Given this list of marker genes ATP2B3, POU4F1, CWF19L1, ABCB7 (ATP binding cassette subfamily B member 7), ATCAY, FRMD4A, CAMTA1, DNAJC19, ITPR1, NADK2, here is a description of the gene set: species: Homo sapiens Nonprogressive cerebellar ataxia Human Gene Set: HP_NONPROGRESSIVE_CEREBELLAR_ATAXIA